The following is a description of a gene set: Contained markers enriched for cell division (e.g., TOP2A, BIRC5, and MKI67) as well as DNA repair. Prol was largely absent or in low abundance in Ben, Low, and Med samples, and present in approximately 4% of the cell population in the two high-grade CCCS (High_1 and High_2), indicating this cluster's association with an advanced tumour phenotype. from publication Su Z, Ho JWK, Yau RCH, Lam YL, Shek TWH, Yeung MCF, Chen H, Oreffo ROC, Cheah KSE, Cheung KSC (PMID 38267611) Human Gene Set: SU_HO_CONV_CENT_CHONDROSARCOMA_C7_PROLIFERATIVE The transformation of benign lesions to malignant tumours is a crucial aspect of understanding chondrosarcomas, which are malignant cartilage tumours that could develop from benign chondroid lesions. However, the process of malignant transformation for chondroid lesions remains poorly understood, and no reliable markers are available to aid clinical decision-making. To address this issue, we conducted a study analysing 11 primary cartilage tumours and controls using single-cell RNA sequencing. By creating a single-cell atlas, we were able to identify the role of endoplasmic reticulum (ER) stress in the malignant transformation of conventional central chondrosarcomas (CCCS). Our research revealed that lower levels of ER stress promote chondrosarcoma growth in a patient-derived xenograft mouse model, while intensive ER stress reduces primary chondrosarcoma cell viability. Furthermore, we discovered that the NF-?B pathway alleviates ER stress-induced apoptosis during chondrosarcoma progression. Our single-cell signatures and large public data support the use of key ER stress regulators, such as DNA Damage Inducible Transcript 3 (DDIT3; also known as CHOP), as malignant markers for overall patient survival. Ultimately, our study highlights the significant role that ER stress plays in the malignant transformation of cartilaginous tumours and provides a valuable resource for future diagnostic markers and therapeutic strategies. studied in species Homo sapiens, and this is the list of marker genes: BARD1, PTMS, HDAC2 (NCBI Gene Id 3066), DEPDC1, NME1, HNRNPAB, KIFC1, TXNDC17, IQGAP3, SMC2, GPM6B, TUBA1B, TPRKB, YBX1, CKS1B, AKAP12 (NCBI Gene Id 9614), MXD3, PPP1R12A, CCNB1, NUTF2 (nuclear transport factor 2), POLR2K, ELOC, H4C3, PKMYT1, NMU, CDT1, CENPN, PARP1, GTSE1, ANLN, HIGD2A, NUSAP1, SKA2, PAFAH1B3, MND1, POLR2L, PCLAF, PRC1, TROAP, CDCA5, PIN1, CDC20 (cell division cycle 20), BCL2L12 (BCL2 like 12), MICOS10, NDC80, TMPO, TPR, RACGAP1, SERTAD4, SPC25, ASPM, KDELR1, H2AX, SUMO3, PSMB4, GPX8, SINHCAF, SIVA1, NUF2, NAXE, ADRB2, SERTAD4-AS1 (SERTAD4 antisense RNA 1), RALY, TXN, AURKA, PCNA, ATP5MF, EMC9, PSME2, TMEM106C, SGO1, SMTN, KIF22, KPNA2, DYNLL1, CDK1, CLSPN, TRIP13, ANP32E, HMGB3, SUMO2, CDKN2D, CKAP2, EDN3, COX6C, BANF1, SNRPF, GLO1, TUBB6, ISYNA1, RBM23, MCM7, TACC3, SNRPG, TPX2, CENPU, KNSTRN, FAAP20, SRSF2, RRM1, SDR39U1, MRPL23, SAC3D1, EBP, FAP, ARL2 (NCBI Gene Id 402), DEK, RRM2, HJURP, BIRC5, CDCA8, KRTCAP2, LMNB2, TRAPPC1, HMGB1, ATP5MC3, ANKRD9, GLRX5, CENPF, ATAD2, HMMR, PIMREG, DYNC2I2, CCNB2, FOXM1, CDKN3, NDUFB2, HMGN2, CDCA4, CALM3, ST3GAL4, KHDRBS1, CKAP2L, SNRPC, ARL6IP1, CYC1, ATOX1, ZWINT, BUB3, LSM7 (NCBI Gene Id 51690), CENPW, BAX, CENPE, TYMS, SRP9, SNRPA, TOP2A, PBK, PSMB3, ELP5, NDUFB11, RAD21, NEK2, RBM8A, ADI1, POLR2J (RNA polymerase II subunit J), ELOB, CCDC34, PHF19, LAMTOR2, GGH, SGO2 (shugoshin 2), TMEM160, ATP5F1E, GUSB, CCT5, MZT1, PXDN, DHFR, RBBP7, DTYMK, PLK1, CENPH, ASF1B, MYO10, CBX1, COL4A2, CDCA3, AURKAIP1 (aurora kinase A interacting protein 1), SNRPB, UBE2C, ITGAE, NDUFS8, HMGN3, PHIP (pleckstrin homology domain interacting protein), NRM, DUT, SMC4, ENY2, BOLA3, PGP, RAD51AP1, DIAPH3, IKBIP, KIF20B, MKI67, CCNA2, TMEM97, CEP55, NGDN, RUVBL2, PSRC1, MAD2L1, HP1BP3, RBMX, ADAM15, KIF23, KIF4A, LDHB, CENPK, UBE2T, PTTG1, RABGGTA, NDUFS6 (NCBI Gene Id 4726), LSM8, TK1, HMGN1, BSG, AURKB, YWHAZ, TUBG1 (NCBI Gene Id 7283), KIF14, SSBP2, METTL9, YIF1B, ARHGAP11A, GMNN, COX8A, CENPA